Given this list of marker genes ABHD6, ZNF330, SLC2A3, DDX17, PFKFB4 (NCBI Gene Id 5210), RPL7A, PKMYT1, RPS10, KATNA1, PCBP1, KIZ, ACTB, PAIP2 (NCBI Gene Id 51247), RPSA, WSB1, ITGA2B, COL5A1, CYP4F2, CDX2, AFDN-DT, TMEM45A, CDH19, RPS6, JUND, UCHL1, BRI3P1, ACRP1, EEF2, GPR135, ATN1, KCNMA1, PSMA1, DCTN2, CCNI, NHERF2, SLC44A4, CRX, CBLN1, TBCA, PSMD11, NEAT1 (NCBI Gene Id 283131), RMDN1, EIF2AK3, FOXC1, HBS1L, LCK, TUBA1A, RAD51D, LDHA, PIM1, BHLHE40, COL7A1, PPP1CA, DCT, CEP290, CHEK2, ALDH1A3, TOP6BL, TMEM184B, CGREF1, PNISR, COA1, WDR59, TBXA2R, PDHA1, RETREG2, RPL34, SMIM11, YWHAE, SQLE, IDH2, COG8, CPNE1, DGUOK, CTSV, ARID4A, CHAF1A, here is a description of the gene set: species: Homo sapiens Special AT-rich binding protein 1 (SATB1) acts as a global regulator of gene expression by recruiting various corepressor or coactivator complexes, thereby establishing a unique chromatin structure at its genomic targets in a context-dependent manner. Although SATB1 acts predominantly as a repressor via recruitment of histone deacetylase 1 (HDAC1) complexes, the precise mechanism of global repression is not clear. Here we report that SATB1 and C-terminal binding protein 1 (CtBP1) form a repressor complex in vivo. The interaction occurs via the CtBP1 interaction consensus motif PVPLS within the PDZ-like domain of SATB1. The acetylation of SATB1 upon LiCl and ionomycin treatments disrupts its association with CtBP1, resulting in enhanced target gene expression. Chromatin immunoprecipitation analysis indicated that the occupancy of CtBP1 and HDAC1 is gradually decreased and the occupancy of PCAF is elevated at the SATB1 binding sites within the human interleukin-2 and mouse c-Myc promoters. Moreover, gene expression profiling studies using cells in which expression of SATB1 and CtBP1 was silenced indicated commonly targeted genes that may be coordinately repressed by the SATB1-CtBP1 complex. Collectively, these results provide a mechanistic insight into the role of SATB1-CtBP1 interaction in the repression and derepression of SATB1 target genes during Wnt signaling in T cells. from publication Purbey PK, Singh S, Notani D, Kumar PP, Limaye AS, Galande S (PMID 19103759) Genes up-regulated in HEK-293 cells (fibroblast) upon knockdown of both CTBP1 and SATB1 by RNAi. Human Gene Set: PURBEY_TARGETS_OF_CTBP1_AND_SATB1_UP